The following is a description of a gene set: Human Gene Set: GSE17721_CTRL_VS_LPS_4H_BMDC_DN mouse primary BMDCs were stimulated with tlr ligands and gene expression changes were profiled on Affymetrix arrays Genes down-regulated in comparison of control dendritic cells (DC) at 4 h versus those stimulated with LPS (TLR4 agonist) at 4 h. from publication Amit I, Garber M, Chevrier N, Leite AP, Donner Y, Eisenhaure T, Guttman M, Grenier JK, Li W, Zuk O, Schubert LA, Birditt B, Shay T, Goren A, Zhang X, Smith Z, Deering R, McDonald RC, Cabili M, Bernstein BE, Rinn JL, Meissner A, Root DE, Hacohen N, Regev A (PMID 19729616) species: Homo sapiens, and this is the list of marker genes: BBOX1, PARP14 (poly(ADP-ribose) polymerase family member 14), HK2, VGLL1, KLK6, EPHB2, CTTNBP2NL, MACROD2, EEF1E1, IL10RB, DYNC1I1, NFKB1, NPR2, HTRA2, ATP6V1E1, RALGDS, SEMA4G, CMTR1, RBM47, IQGAP1, GAPDHS, ACTN1, NRAP, DUOXA1, CD70, ZFP62, GOSR1, RILPL1, ARF6, NR4A1, CELSR1, HOXA4, ATAD2B, CAVIN3, NRROS, GABARAPL2, LZTFL1, IL18, LHB, STAT5A, ATM, DTX2 (deltex E3 ubiquitin ligase 2), ARHGAP17, MMP14 (NCBI Gene Id 4323), NFATC2IP, TRAT1, CEP112, GINM1, NAMPT, SOCS1 (suppressor of cytokine signaling 1), TCF4, HINFP, EGFR, SLC28A2, SMAGP, SLC39A8, RNF114, FMO1, PI4K2A, TRMT112, DACH1, PSD, PSMA4, LYPD8, SIAH1, SCX, GRHL2, BMX, UBE2E1, RBM43, ATL3, TRAF5, GC, VCL, CSDE1, CCNL1, MEP1B, C19orf12, HIF1A, JARID2, FRMD6, GCA, PLEKHA3, BIRC3, MYF5, TSPAN15, CLEC5A (C-type lectin domain containing 5A), FZD9, PDSS1, STXBP3, FAM107B, TMEM9, PROCR, CHD1, STXBP1, SLC6A13, ZRSR2, RAB33B, TRA2B, APBB2, SYAP1, H3C7, OLR1, FCER1A, WASF3, ZNF689, NOS2, PLEKHA5, ITGB1BP2, CCNJ, SLAMF9, ORM1, FABP9, KDR, EPX, EBI3, RRAS2, NUDT9, BCL2L1, FAM241B, IER3 (immediate early response 3), WNT3A, ELOC, GYPC, KEAP1, ATP1B4, SPDEF, TJAP1, HAND1, COL5A1, ZC3H11A, KCNH7, SLC40A1, CARHSP1, DHX58, SAPCD1, ARMCX1, ELAVL4, USP17L2, GBP2, HNF1B, C5orf52, LMO4, PLCL2, HOXC13, ADCY4, USP15, ICOS, ESR1, IFT172, MED28, FOXP1, ADCY2, E2F8, PLEKHF2 (pleckstrin homology and FYVE domain containing 2), CES1, ARHGAP35, CA8, TIMP1, BMPR1A, ALDOAP2, METAP1, DPP6 (NCBI Gene Id 653748), TRIM26, ELL2, PLXNB3, SERPINE1, SLC44A1, NECTIN2, M1AP, RAB32, HBG2, C11orf68, SQSTM1, RNF19A, RCAN2, RS1, SOWAHC, TPR, HRH3, RAG1, CRYBA1, IL23A, RBFOX3, NKD2, CCDC65, SERPINB9, UTP3, ACTL6B (NCBI Gene Id 51412), FAAH, IRGM, DUSP16, GPR87, PTPRA, USHBP1, STAU1, CHRNA5, RNFT1, MYT1L, MYH1